The following is a description of a gene set: species: Homo sapiens Glycogen synthesis Human Gene Set: REACTOME_GLYCOGEN_SYNTHESIS, and this is the list of marker genes: PGM1, GYS2, GYS1, EPM2A, UGP2, NHLRC1, GYG2, UBB (ubiquitin B), UBC, RPS27A, GYG1, PPP1R3C, UBA52, GBE1